Given this list of marker genes IRAK1, IRAK2, RIPK2, BTRC, MAPK3, TRAF6, CREB1, MAPK7, MAPK1, UBB, FBXW11, RPS6KA3, RPS6KA5, MAPK11, PPP2CB, MAP2K6, IKBKB, TAB3, MAPK9, UBE2N, VRK3, MEF2A, PPP2CA, DUSP3, RPS6KA1, MAP2K1, TAB2, DUSP7, ELK1, TAB1, ATF1, UBE2V1, DUSP6, MAP3K7, MAPKAPK2, MAP2K7, CUL1, MAP3K8, UBA52, IKBKG, PPP2R1A, MEF2C, NFKB1, PPP2R1B, MAP2K3, MAPKAPK3, UBC, RPS6KA2, MAPK10, TNIP2, MAP2K4, NOD2, ATF2, NOD1, CHUK, FOS, MAPK14, RPS27A, JUN, PPP2R5D, MAPK8, DUSP4, SKP1, here is a description of the gene set: The mitogen activated protein kinase (MAPK) cascade, one of the most ancient and evolutionarily conserved signaling pathways, is involved in many processes of immune responses. The MAP kinases cascade transduces signals from the cell membrane to the nucleus in response to a wide range of stimuli. <p>There are three major groups of MAP kinases<ul><li>the extracellular signal-regulated protein kinases ERK1/2, <li>the p38 MAP kinase<li> and the c-Jun NH-terminal kinases JNK.</ul><p>ERK1 and ERK2 are activated in response to growth stimuli. Both JNKs and p38-MAPK are activated in response to a variety of cellular and environmental stresses. The MAP kinases are activated by dual phosphorylation of Thr and Tyr within the tripeptide motif Thr-Xaa-Tyr. The sequence of this tripeptide motif is different in each group of MAP kinases: ERK (Thr-Glu-Tyr); p38 (Thr-Gly-Tyr); and JNK (Thr-Pro-Tyr).<p>MAPK activation is mediated by signal transduction in the conserved three-tiered kinase cascade: MAPKKKK (MAP4K or MKKKK or MAPKKK Kinase) activates the MAPKKK. The MAPKKKs then phosphorylates a dual-specificity protein kinase MAPKK, which in turn phosphorylates the MAPK.<p>The dual specificity MAP kinase kinases (MAPKK or MKK) differ for each group of MAPK. The ERK MAP kinases are activated by the MKK1 and MKK2; the p38 MAP kinases are activated by MKK3, MKK4, and MKK6; and the JNK pathway is activated by MKK4 and MKK7. The ability of MAP kinase kinases (MKKs, or MEKs) to recognize their cognate MAPKs is facilitated by a short docking motif (the D-site) in the MKK N-terminus, which binds to a complementary region on the MAPK. MAPKs then recognize many of their targets using the same strategy, because many MAPK substrates also contain D-sites.<p>The upstream signaling events in the TLR cascade that initiate and mediate the ERK signaling pathway remain unclear. part of: Interleukin-17 signaling; MyD88 cascade initiated on plasma membrane; MyD88:MAL(TIRAP) cascade initiated on plasma membrane; TRAF6 mediated induction of NFkB and MAP kinases upon TLR7/8 or 9 activation; TRIF (TICAM1)-mediated TLR4 signaling ; Toll Like Receptor 3 (TLR3) Cascade species: Homo sapiens Reactome Pathway: MAP kinase activation